The following is a description of a gene set: from publication Yevshin I, Sharipov R, Kolmykov S, Kondrakhin Y, Kolpakov F (PMID 30445619) Human Gene Set: LAMTOR5_TARGET_GENES Genes containing one or more binding sites for (LAMTOR5) in their promoter regions (TSS -1000,+100 bp) as identified by GTRD version 20.06 ChIP-seq harmonization. studied in species Homo sapiens, and this is the list of marker genes: MT-TA, MT-TN, MT-TY, MT-TE, MT-TT, MT-TC, MT-TP, MTCO3P12